The following is a description of a gene set: Reactome Pathway: Synthesis of PC part of: Glycerophospholipid biosynthesis electronically inferred by orthology from the curated human pathway This event has been computationally inferred from an event that has been demonstrated in another species.<p>The inference is based on the homology mapping from PANTHER. Briefly, reactions for which all involved PhysicalEntities (in input, output and catalyst) have a mapped orthologue/paralogue (for complexes at least 75% of components must have a mapping) are inferred to the other species. species: Mus musculus, and this is the list of marker genes: Pcyt1b, Slc44a3, Chpt1, Stard10, Pemt, Pcyt1a, Abhd3, Slc44a2, Slc44a4, Chkb, Chka, Mfsd2a, Csnk2b